The following is a description of a gene set: Severe B lymphocytopenia species: Homo sapiens A severe form of B lymphocytopenia in which the count of B cells is very low or absent. Human Gene Set: HP_SEVERE_B_LYMPHOCYTOPENIA, and this is the list of marker genes: NFKB2, DCLRE1C, RAG1, ADA, PRIM1, RAG2